The following is a description of a gene set: species: Homo sapiens from publication Chen Y, Wang X (PMID 31504780) Genes predicted to be targets of miRBase v22 microRNA hsa-miR-371a-3p in miRDB v6.0 with MirTarget v4 prediction scores > 80 (high confidence targets). Human Gene Set: MIR371A_3P, and this is the list of marker genes: EXOC8, MAPK6, AGO1, PFN2, TOB1, GSG1, ZNF213, PHF1, PAFAH1B1